The following is a description of a gene set: The chemical reactions and pathways involving alditol phosphates, any phosphorylated polyhydric alcohol derived from the acyclic form of a monosaccharide by reduction of its aldehyde or keto group to an alcoholic group. Mouse Gene Set: GOBP_ALDITOL_PHOSPHATE_METABOLIC_PROCESS studied in species Mus musculus, and this is the list of marker genes: Gykl1, Gk5, Gk (glycerol kinase), Slc37a2, Gpat2, Gpd1, Abhd6, Gpd2, Acp6, Gk2, Gpat3, Gpd1l